Given this list of marker genes Tent4b, Tent4a, Zcchc7, Mtrex, Zcchc8, here is a description of the gene set: Mouse Gene Set: GOCC_TRAMP_COMPLEX species: Mus musculus A multiprotein complex having distributive polyadenylation activity of a variety of RNA substrates including hypomodified and incorrectly folded tRNAs, pre-snRNAs, pre-snoRNAs, incorrectly spliced or processed pre-mRNAs, cryptic unstable transcripts (CUTs), pre-rRNAs and rRNA fragments released as part of rRNA processing. In S. cerevisiae, the complex consists of either Pap2 (also known as Trf4) or Trf5, Air1 or Air2, and Mtr4, and is involved in RNA 3'-end processing and in RNA surveillance and quality control.